Given this list of marker genes BUB1B, ATAD3A, PCLO, SIX3, CEP85L, SMARCC2, MBTPS2, AFF3, TKFC, TSEN15, NCAPG2, EBF3, CCDC47, MYO5A, DYNC2I1, LMNB1, MTM1, RPL10, NDP, PIBF1, TUBB2A, MAN1B1, RFX7, PRRX1, RAP1B, ATP6V0A1, NODAL, CWF19L1, ARL13B, MGAT2, ARID1B, RPE65, WDR73, NOP10, GFM2, FAM149B1, OFD1, MBD5, SLC25A24, AIPL1, KATNIP, KIF14, PIK3CA, ERCC1, CEP120 (centrosomal protein 120), ATP6V1B2, CEP164, MYO7A, ATP6V1A, PPP1R21, PPFIBP1, NSUN6, SLC25A19, FAT4, MFSD2A, MAN2C1, TCTN3, EBP, NPHP1, DYNC2I2, CSF1R, CENPE, PCGF2, ZIC1, GDF6, YME1L1, SEMA6B, DPAGT1, TMEM216, RD3 (RD3 regulator of GUCY2D), HERC1, MAPK8IP3 (NCBI Gene Id 89855), DKC1, MED11, TRAPPC9, CTBP1, TERT, RBM8A, COL4A1, CENPF, CCDC32, TMEM231, CEP41, ZNF592, PSAT1, MSTO1, SASS6, EIF4A2, RAPSN, BUB1, IER3IP1, SLC25A1, TMEM218, GTPBP2, RAB34, CHD7, COASY, SLC1A3, FANCB, KCNJ13, IGF2, UFSP2 (UFM1 specific peptidase 2), CRB1, MRE11, TUBB2B, BRF1, DYNC1H1, IFT80, USH1C, TFAP2A, GPX4, PGAP2, VPS4A, RAD21, JAM3, USP9X, RAB3GAP2, MEF2C, ATP9A, HESX1, PPP2R1A, RAB3GAP1, CLCN3, FLNA, HRAS, EPG5, PDHB, B3GALNT2, CEP55, SACS, VRK1, FKTN, SNX14, VLDLR, NONO, MAGEL2, MACF1, SRPX2, CRX, GPKOW, ERCC2, STAT2, ALG3, OTUD5, MID1, VPS51, SMARCA4, USP45, PTF1A, APC2, COG8, TSEN54, ATP2B3 (NCBI Gene Id 492), GJB2, SLC35A2, EN1, CSPP1, PPP1CB, TOGARAM1 (NCBI Gene Id 23116), THG1L, RTTN, SOX4, TAF4, INTS8, FRMD4A, OTX2, RPGRIP1L, DPF2, MAST1, SOX11, PIGT, NAGA, MVK, ALG12, TRAPPC12, CDC42BPB, IFT140, POMT2, DMXL2, THOC2, CDK5, ELN, CPT2, TBCK, LARGE1, ATP6V1E1, LAMB1, EXOSC9, RHOBTB2, FDXR, ABCB7, IMPDH1, TMCO1, DPH2, INTS1, GPSM2, SETD2, DYNC2H1 (NCBI Gene Id 79659), DOCK6, SON, MAP2K2, BRD4, ERCC6, ATN1, PHGDH, GLI3, FGFR1, GRIA3, CAMTA1, NDUFA6 (NCBI Gene Id 4700), B4GALT1, HMBS, GEMIN4, PDE6D, KPNA3, FAR1, DCHS1, CACNA1G, KIF7, NFIX, CBY1, GPHN (NCBI Gene Id 57566), ERCC5, POLR3A, TBC1D24, MYOD1, TCTN2, ASPM, TINF2, RAB18, SMG9, ASXL3, SEMA3E, PRKDC, PCYT1A, ARSI, CEP290, OCLN, SIL1, PAFAH1B1, RPS6KA3, INPP5E, WLS, CLXN, MARS2, SLC25A46, TMEM107, RARS2, EXOC2, AP1S2, MINPP1, BUB3, SUOX, H3-3A, RBM10, PACS1, PI4KA, NEK1, UFC1, TP53RK, RTEL1, MYMX, MAPKAPK5 (NCBI Gene Id 8550), TMEM237, EHMT1, GPAA1, TMTC3, DHFR, CIT, OPHN1, AFG3L2, PRDM13, EVC2, DHCR7 (NCBI Gene Id 6589), BMP4, CDC40, RPGRIP1, FTH1 (NCBI Gene Id 92182), SPTBN2, ARID2, ATXN2, NDE1, TUBB4B, DENND5A, MUSK, ATR, HHAT, MKS1, AMPD2, AHI1, NIPBL, FIG4, HDAC6, ADGRV1, ADGRG1, MYMK, GMPPB, PIGA, MDH1, ASNS, TAF1, HYLS1, TRIP13, MTHFR, STUB1, EXOSC8, TCTN1 (tectonic family member 1), B4GAT1 (NCBI Gene Id 11041), VAC14, CDKN1C, INTS11, CCDC22, IFT74, CC2D2A, TUBB3, C2CD3, ROGDI, SEPSECS, EXOSC1, KIF21A, KRAS, OXR1, VPS13B, EXOSC2, PCDH15, LCA5, GUCY2D, TMEM67, DOK7, PLP1, PPIL1, L2HGDH, EVC, HNRNPH2, IQCB1, ATP5F1A, WDR35, COG1, TBC1D20, AHCY, POLR1A, RAC1, GJA1, TRMT10A, TSEN34, NSD1 (NCBI Gene Id 6797), POMK (NCBI Gene Id 84197), ZNF335, LRAT, KNL1, ALG6, KARS1 (NCBI Gene Id 3735), VANGL2, TRRAP (NCBI Gene Id 8295), EZH2 (enhancer of zeste 2 polycomb repressive complex 2 subunit), NSRP1, ASXL1, ERF, ATP6V0A2, TMEM138, RXYLT1, RDH12, FBXL4, NMNAT1, SUFU, FLVCR2, FOSL2, PPP1R15B, TAF6, PGAP1, EXOC7, MLXIPL, ZNF292, CAMSAP1, PACS2, ALX4, BLTP1, ZEB2, PLG, KIDINS220, ITPR1, GPC3, ARMC9, WHRN, HNRNPH1, DAG1, COL3A1, UBE3C, CHMP1A, WDR26, SAMD9L, RELN, GPC4, MICOS13, ARHGEF2, SHQ1, PMM2, RBBP8, COQ4, TUBA1A, SMC1A, NUP37, KCNQ1OT1, ERMARD, RNU4ATAC, KCNQ1, ABAT, TSEN2, NPHP3, HDAC8, RAB11B, POU4F1, SOX3, L1CAM, TXNDC15, ARL3, CPLANE1, TWIST1, CIB2, FOXC1, KIAA0753, LETM1, PTRH2, TUBB, ATG5, PARN, WASHC5, DDX3X, FANCL, ZIC3, CPLX1, TERC, PIEZO2, VARS2, DPH1, CPSF3, PDZD7, WAC, KIAA0586, B9D1, CTNNA2, POMGNT1, KMT2C, ACD, RNF113A, B9D2, ACBD6, SPATA7, GOT2, FTO, VPS35L, RNU12, TAPT1 (transmembrane anterior posterior transformation 1), CEP104, POGZ, PTEN, FKRP, BCOR, WDR81, RORA, ATG7, TNPO2, SMARCD1, DHX37, CDH23, TBC1D23, POMT1, BICD2, CRPPA, NRAS, TOPORS, SMARCB1, LONP1, DPM2, FGFR3, RERE, ZBTB11, LRPPRC, USP18, USH2A, ROBO1, MPL, ROBO3, NSD2, LRRC32, HNRNPR, ESCO2, WNT1, GRM1, CILK1, TUBGCP6, SOX2, PEX2, ACY1, PLK4, GJB6, NUP88, SMC3, TUBGCP4, STAG2, WARS2, ARNT2, PIGG, PLCH1, ARID1A, ZNF423, DPH5, TULP1, LAMA1, PROKR2, FGFR2, POMGNT2, SRD5A3, CHD6, PMPCA, MAB21L1, LNPK, EOMES, CARS2, EXOSC3, AGTPBP1, CASK, CEP57, SYT2, CNTNAP2, SLC18A3, PIGN, KIF5A, ESPN, PIGU, NELFA (NCBI Gene Id 7469), CDC42, IFT172, TOE1, SMARCE1, USH1G, SMPD4, ATCAY, DPYSL5, here is a description of the gene set: Aplasia/Hypoplasia of the cerebellum Human Gene Set: HP_APLASIA_HYPOPLASIA_OF_THE_CEREBELLUM species: Homo sapiens